Given this list of marker genes Lrwd1, Orc3, Mcm2, Orc6, Orc5, Orc4, Orc1, Orc2, here is a description of the gene set: species: Mus musculus Mouse Gene Set: GOCC_ORIGIN_RECOGNITION_COMPLEX A multisubunit complex that is located at the replication origins of a chromosome.